Given this list of marker genes TSPO, ACTN2, NOS2, NPPA, NEFL, CNGA1, CAMK2G, CNGA2, IL1B, NPR1, XIAP, NFKBIA, CAMK2B, CNGA3, GUCY1B1, CNGA4, CAMK2A, BCL2, CNGB1, GRIN2C (glutamate ionotropic receptor NMDA type subunit 2C), GUCY1A2, CREB1, NFKB1, NPPB, CAMK2D, GRIN1, CNGB3, GRIN2D, CALM1, GRIN2B, CYCS, GUCY1A1, PPID, PDE2A, PDE3A, BAD, AKAP9, IFNG, CASP9, TNF, PRKG2, NOS3, RELA, GRIN2A, DLG4, NOS1, GUCY1B2, here is a description of the gene set: NO/cGMP/PKG mediated neuroprotection studied in species Homo sapiens Human Gene Set: WP_NOCGMPPKG_MEDIATED_NEUROPROTECTION